Given this list of marker genes Ighg2b, Zp3, H2-T23, Npy, Fcgr2b, Pla2g2d, Ighg1, Adcyap1, Fcer1a, Ccr7, Fcgr3 (NCBI Gene Id 14131), Spn, Selenos, Btk, Cnr1, Park7, Fcer1g, Fut7, Fcgr1, Il20rb, Npy5r, C3, here is a description of the gene set: Mouse Gene Set: GOBP_REGULATION_OF_ACUTE_INFLAMMATORY_RESPONSE_TO_ANTIGENIC_STIMULUS Any process that modulates the frequency, rate, or extent of an acute inflammatory response to an antigenic stimulus. studied in species Mus musculus